The following is a description of a gene set: Downstream signaling of activated FGFR2 Mouse Gene Set: REACTOME_DOWNSTREAM_SIGNALING_OF_ACTIVATED_FGFR2 studied in species Mus musculus, and this is the list of marker genes: Hras, Frs2, Fgf6, Fgf8, Kras, Pik3ca, Fgf20, Fgf22, Sos1, Fgf18, Fgf10, Fgf9, Fgf7, Fgf1, Gab1 (NCBI Gene Id 14388), Fgf4, Ptpn11, Grb2, Fgf17, Fgf5, Fgf2, Shc1, Fgf23, Frs3, Pik3r1, Fgf16, Fgf3, Plcg1 (NCBI Gene Id 99130)